Given this list of marker genes Bet1, Sec24a, Sec31a, Trappc5, Ppp6c, Scfd1, Ctsc, Sec24d, Areg, Sec24b, Folr1, Lman1l, Trappc9, Gorasp1, Col7a1, Cnih2, Sec31b, Rab1b, Lman1, Tmed10, Golga2, Cnih3, Sec16b, F8, Nsf, Lman2l, Uso1, Rab1a, Tgfa, here is a description of the gene set: Reactome Pathway: COPII-mediated vesicle transport electronically inferred by orthology from the curated human pathway This event has been computationally inferred from an event that has been demonstrated in another species.<p>The inference is based on the homology mapping from PANTHER. Briefly, reactions for which all involved PhysicalEntities (in input, output and catalyst) have a mapped orthologue/paralogue (for complexes at least 75% of components must have a mapping) are inferred to the other species. studied in species Mus musculus part of: ER to Golgi Anterograde Transport